Given this list of marker genes CPVL, MPP1, CD180, CNRIP1, TREML1, MAPKAPK5-AS1, CD9, NUCB1, FABP4, CYB5D2 (cytochrome b5 domain containing 2), CFD, EIF3L, SLC39A10 (NCBI Gene Id 57181), TEPSIN, EPRS1, OXA1L, DEPTOR, LSP1, FRMD4B, AVPI1, HPS3, ABCC5, DPEP2, PMFBP1, RNF170, TUT7, EPAS1, CCDC14, ZNF703, EPHB2, ERP29, FNDC3A, MRTFB, TBC1D2, TXNIP, TMEM134, RFX7, TMT1A, CASP10, GAS2L3, FAM78A, VPS13C, CIITA, LY86, PAN2, CAT, SNX29, CD300LB, ALAD (NCBI Gene Id 210), HADH, SLC16A5, PLA2G15, OAS1, ZFP36L2, FECH, HLA-DMB, FABP5, METTL25, HMGN3, SHMT1, CD244, CIAO2A, GRN, WDR7, GSTK1 (glutathione S-transferase kappa 1), CD300A, KCNJ5-AS1, PLEKHA2, ACSL6, LTC4S, RAB42, SIGLEC15, MAML3, SPARC, A2M, MS4A6A, ACADM, HHEX, STMN1, HERPUD1, DCLRE1C, SELENOP, SLC7A8, NR1D2, TLR7, JPT1, APOBEC3C, APOC1, SPIN1, KCNJ1, GNA13, AMDHD2, HAVCR2, PDK3, CAPN3, CMTM7, OSBPL1A, CLEC10A, DHRS9, ECI2, EPS8, CD302, SULF2, CADM1, HLA-DMA, TM7SF3, NCOA7, HAL, BACE1, PTPN18, CRTAP, TNFSF13B, CHN2, TNFRSF11A, ADA2, TASOR, GBP2, SLC17A5, EPHX1, PCYOX1, S100Z, GDPD1, CA11, REPS2, DBP, CHST13, SGK1, ACTMAP, PDK4, ITGB5, CLEC3B, AIG1, PLCB1, SPOP, FABP3, ATP1B1, SHB, MEF2C, KLF7, FAM228B, ANGPT1, MAPRE2, CCNY, TMEM126B, MRO (NCBI Gene Id 83876), DGLUCY, ATP5IF1, HLA-A, TPK1, PHYH, RPS6KA2, PSEN2, ASRGL1, SRD5A3 (steroid 5 alpha-reductase 3), PABPC4, OSBPL3, LINC00324, GINS1, PTGR3 (NCBI Gene Id 284273), LGALS3, ING2, MIF4GD, ACAA1, HGF, CEBPA, TREM2, ABHD14A, CHEK2, MXI1, ME3, ABCA6 (ATP binding cassette subfamily A member 6), RAB38, IQGAP2, RASA1, TESK1, SARAF, IRF2BPL, ADGRD1, HEXA, GGTA1, TCEAL1, CRHBP, SESN1 (NCBI Gene Id 27244), SORBS3, TBC1D9B, CD101, AHSA2P (activator of HSP90 ATPase homolog 2, pseudogene), PPT1 (NCBI Gene Id 5538), MPPE1, KIF20B, CDK5RAP3, OGFRL1, RNASET2, LINC00865, MKLN1, STARD13, PFDN5, HLA-DRB1, here is a description of the gene set: species: Homo sapiens from publication Lin JX, Li P, Liu D, Jin HT, He J, Ata Ur Rasheed M, Rochman Y, Wang L, Cui K, Liu C, Kelsall BL, Ahmed R, Leonard WJ (PMID 22520852) Cytokine-activated STAT proteins dimerize and bind to high-affinity motifs, and N-terminal domain-mediated oligomerization of dimers allows tetramer formation and binding to low-affinity tandem motifs, but the functions of dimers versus tetramers are unknown. We generated Stat5a and Stat5b double knock-in (DKI) N-domain mutant mice that form dimers but not tetramers, identified cytokine-regulated genes whose expression required STAT5 tetramers, and defined consensus motifs for dimers versus tetramers. Whereas Stat5- deficient mice exhibited perinatal lethality, DKI mice were viable, indicating that STAT5 dimers were sufficient for survival. Nevertheless, STAT5 DKI mice had fewer CD4+CD25+ T cells, NK cells, and CD8+ T cells, with impaired cytokine-induced proliferation and homeostatic proliferation of CD8+ T cells. DKI CD8+ T cell proliferation following viral infection was diminished and DKI Treg cells did not efficiently control colitis. Thus, tetramerization of STAT5 is dispensable for survival but is critical for cytokine responses and normal immune function. Human Gene Set: GSE36888_STAT5_AB_KNOCKIN_VS_WT_TCELL_IL2_TREATED_2H_UP Genes up-regulated in T cells stimulated by IL2 for 2h: STAT5 double knock-in versus wildtype.